Given this list of marker genes GNAI2, OPRK1, GRM6, RIC8A, GPR146, GRM4, ADGRG6, CHRM5, CHRM3, HTR5A, S1PR1, SSTR2, HTR1D, GRM5, MARCO, P2RY1, ADORA1, MIR30E, GRM2, INSL3, GNAI1, NPY1R, CHRM1, ADCY5, HTR1A, PSAP, FLNA, HTR1E, GRM7, TAAR1, MIR133A1, GRIK3, FPR2 (formyl peptide receptor 2), DRD4, GRM3, EDNRA, FFAR3, OPRL1 (NCBI Gene Id 4987), P2RY12, FSHR, RGS2, MTNR1A, MCHR1, NPY2R, APP, DRD2, PTGDR2, PRKACA, GPR37L1, OPRD1, PTGER4, GPR37, OXER1, GPR176, RGS1, HRH3, PDE2A, ADRA2A, GNAO1, GRM8, GNAI3, APLNR, EDN1, ITGB3, LPAR1, HTR4, OPRM1, ADCY6, GNAZ, HRH4, HTR1B, DRD3, CHRM4, S1PR3, GABBR1, CASR, AKAP12, HTR1F, PRMT5, PSAPL1, RXFP2, AKAP5, GABBR2, CHRM2, CORT, PALM, GRM1, here is a description of the gene set: Human Gene Set: GOBP_ADENYLATE_CYCLASE_INHIBITING_G_PROTEIN_COUPLED_RECEPTOR_SIGNALING_PATHWAY A G protein-coupled receptor signaling pathway in which the signal is transmitted via the inhibition of adenylyl cyclase activity and a subsequent decrease in the intracellular concentration of cyclic AMP (cAMP). studied in species Homo sapiens